The following is a description of a gene set: Mouse Gene Set: LEE_TARGETS_OF_PTCH1_AND_SUFU_UP Genes up-regulated in medulloblastoma tumors from animals with inactivating mutations of one copy of PTCH1 or SUFU in conjunction with TP53 loss. from publication Lee Y, Kawagoe R, Sasai K, Li Y, Russell HR, Curran T, McKinnon PJ (PMID 17452975) The Sonic Hedgehog (SHH) signaling pathway is indispensable for development, and functions to activate a transcriptional program modulated by the GLI transcription factors. Here, we report that loss of a regulator of the SHH pathway, Suppressor of Fused (Sufu), resulted in early embryonic lethality in the mouse similar to inactivation of another SHH regulator, Patched1 (Ptch1). In contrast to Ptch1+/- mice, Sufu+/- mice were not tumor prone. However, in conjunction with p53 loss, Sufu+/- animals developed tumors including medulloblastoma and rhabdomyosarcoma. Tumors present in Sufu+/-p53-/- animals resulted from Sufu loss of heterozygosity. Sufu+/-p53-/- medulloblastomas also expressed a signature gene expression profile typical of aberrant SHH signaling, including upregulation of N-myc, Sfrp1, Ptch2 and cyclin D1. Finally, the Smoothened inhibitor, hedgehog antagonist, did not block growth of tumors arising from Sufu inactivation. These data demonstrate that Sufu is essential for development and functions as a tumor suppressor. species: Mus musculus, and this is the list of marker genes: Cavin2, Cklf (NCBI Gene Id 75458), C4b, Atoh1, Katnip, Cdh20, Ppan, Cdca7, Lap3, Ctss, Gpnmb, Mcm6, Ccnd2, Gm42047, Gli2, Ybx3, Rpl23, H2-Aa, Hsd11b2, Tbata, Rnd3, Socs2, Eif4ebp1, Cdk6, Rad51ap1, Sufu, C1qb, B2m, Plekho2, Irs1, Magohb, Mthfd2, ENSMUSG00000127189, Map2k6, Sstr2, C1qa, Akna, Lrig3, Ptch2, Ier5, Mical1, Rps27, Fam210b, Kmt5a, Ddr2 (NCBI Gene Id 98699), Sfrp1, Tshz2, Lyz2, Frmd4b, Ccnd1, Mcm2, Fzd2, Sox18, Mycn, Zeb1, Gli1, Pole, Hk2